The following is a description of a gene set: studied in species Homo sapiens The process, occurring in the embryo, by which the anatomical structures of the forelimb are generated and organized. The forelimbs are the front limbs of an animal, e.g. the arms of a human. Human Gene Set: GOBP_EMBRYONIC_FORELIMB_MORPHOGENESIS, and this is the list of marker genes: TBX5, RPGRIP1L, RDH10, CACNA1C, OSR1, RUNX2, ALDH1A2, SHH (sonic hedgehog signaling molecule), NIPBL, HOXA11, RECK, MSX1, RSPO2, ALX4, ZNF358, WNT3 (NCBI Gene Id 7473), SHOX2, TFAP2A, ALX3, CTNNB1, TP63, CRABP2, LNPK, IFT122, TWIST1, OSR2, TBX3, HOXD9, HOXA13, EN1, MSX2 (NCBI Gene Id 8053), HOXA9, WNT7A